Given this list of marker genes Stxbp1, Slc38a2, Dtnbp1, Rab3gap1, Kmo, here is a description of the gene set: Mouse Gene Set: GOBP_REGULATION_OF_GLUTAMATE_SECRETION_NEUROTRANSMISSION Any process that modulates the frequency, rate or extent of glutamate secretion, neurotransmission. species: Mus musculus